The following is a description of a gene set: Human Gene Set: GOBP_PEPTIDYL_LYSINE_DIMETHYLATION The methylation of peptidyl-lysine to form peptidyl-N6,N6-dimethyl-L-lysine. studied in species Homo sapiens, and this is the list of marker genes: CSKMT, EHMT2, SETD7, SMYD2, EHMT1